The following is a description of a gene set: Reactome Pathway: Activation of ATR in response to replication stress part of: G2/M Checkpoints electronically inferred by orthology from the curated human pathway This event has been computationally inferred from an event that has been demonstrated in another species.<p>The inference is based on the homology mapping from PANTHER. Briefly, reactions for which all involved PhysicalEntities (in input, output and catalyst) have a mapped orthologue/paralogue (for complexes at least 75% of components must have a mapping) are inferred to the other species. species: Mus musculus, and this is the list of marker genes: Rad1, Hus1, Rfc3, Rpa1, Orc5, Cdc6, Mcm4, Mcm2, Cdc45, Orc3, Mcm8, Orc4, Orc1, Cdc7, Cdc25c, Dbf4, Rad9a, Mcm7